Given this list of marker genes SVIP, ARHGAP42, NOD1, PLEKHA1, FYCO1, CDH10, DNAAF9, CYLD, AHR, MAP3K5, INO80B (NCBI Gene Id 83444), ZDHHC2, MUTYH, TBX2, CDK5, TTYH1, ZFYVE27, TTYH2, PLPP6, MBOAT2, SAE1, OSTM1, RBM18, ELAPOR1, BCAS3, N4BP2L1, ACTB, BCAR1, EEIG1, WIPI1, ATP13A2, RCOR2, SLC31A2, HELZ, NAV2, VPS50, ARHGAP5, SORL1, TBC1D23, PLEKHG1, TMEM151A, IFFO1, UBFD1, H2AC8, GDI1, ACBD5, ARL4A, TMEM198B, SSC5D, CCDC13, SLC17A5, MATN2, FAM174B, SH3BP4, BCHE, DAB2, TET2, BMP1, HTRA3, ULK1, IPO7, IMPA2, SYT11, MFRP, PPP2R2A, HIPK2, ZNF24, BAK1 (BCL2 antagonist/killer 1), SLC35A3, COL11A2, ATP8A1, SLC25A10, GLIS2, JAM3 (junctional adhesion molecule 3), CFAP410, PKIG, WWP2, GPR37, HECTD4, RALGDS, DHRS1, TSC22D1, ABLIM1, PIGB, PCDHB13, HELLS, PPP2R2B (protein phosphatase 2 regulatory subunit Bbeta), TPPP, PXMP4, GOLPH3L, SAMD5, CAMSAP2, ZEB2, WDR1, GLRB, HERPUD2, DBP, SYNPO, CERS6, TMEM150A, BTG1, CARD19, TM7SF3, TNFAIP6, SMPD2 (NCBI Gene Id 6610), IGSF9B, PDGFA, NBEAL1, ANKRD44, PHYHIPL, TNFRSF21, H2AZ2, FAM234B, C4A, ABCC10, TUBB4A, WDR83, CEP78, CFAP300, DCT, PAFAH1B1, TMEM108, ARHGEF25, GRB14, USP6NL, NOPCHAP1 (NOP protein chaperone 1), MALAT1, TJAP1, PCDH17, RUSC1 (RUN and SH3 domain containing 1), SEC16B, CPT1A, STRADA, COPS9, CORO7, AFAP1, TERF1, UQCC3, GAREM2, SEC14L3, ABTB1, ICMT, ATMIN, TANGO2, AK1, NREP, CDV3, PXDN, NARF, SDSL, PHLDB1, BBIP1, COL6A1, AGO4, IFI27L2, PCDHGC4, LIN54, ACAA1, VPS51 (NCBI Gene Id 739), SORBS3, BTRC, MAP6D1, SMG5, RBM12, COA8, DOCK9, H3C15, EFCAB14, ARL5B, UBASH3B, CERK, RNF128, RUFY3, NAGA, INPPL1, SLC1A1, CYB5A, RHOG, SLC2A3, PRKCQ, GRID2, DNER, TAMALIN, NKAIN1, HOMER1, GSK3B, HSPA1B, BNIP3 (NCBI Gene Id 664), MYO18A, NDUFAF3, CFAP68 (NCBI Gene Id 737), PRNP, SNX5, MYCBP, COQ3, ELAVL1 (ELAV like RNA binding protein 1), CADM2, RND2, DDR1, FOXP1, ERBIN, MBOAT1 (NCBI Gene Id 154141), H2BC11, CCDC28A, RNF144A, GAB1, BAZ2B, PARP3, S100A1, PIK3R3 (NCBI Gene Id 8503), DENND5A, COL4A5, KDM6A, MAN2B1, ATPAF1, NCAM2, IGSF11, ZMAT1, NR1D2, TXNIP, PLEC, FAM13C, MKRN1, EYA3, CCSAP, LYPD1, SERPINI1, RETREG3, CDC42EP3, LRRN3, MPZL1, CCL5, WASF1, KCNA1, KIFC2, ABCC5, NISCH, GALC, RTN4, DIPK1A, MSI2, TCTA, H3C13, INPP5E, SKIL, EPS8, SLC25A27, CEP95 (centrosomal protein 95), CCNT2, LHFPL2, LGALS9, FMNL2, SGCB, EEF1AKMT2, GADD45B, KCTD13, VAT1, TAFA2, VPS37A, MAD2L1 (NCBI Gene Id 4085), PPT1, ENPP5, MT3, TOMM20, RGS3 (regulator of G protein signaling 3), DNMT3A, THSD7A, ELDR, PDE9A, THOC2, GDF1, FKBP8, IKZF5, UGT8, CPNE2, ABI1, SEMA6D, CD81, LRP4, FAM32A, NHSL3, TMSB15B, FBXO6, JAM2, NCALD, SERBP1, AATK, DBN1, CNKSR3, LRRC8B, PRKAR2A, KLHL30, TMEM8B, CKLF, TRIO, SCN8A, TNR, MYRF, MTMR4, MAF (NCBI Gene Id 4094), SERINC5, SRGAP1, FOXP2 (forkhead box P2), PDK1, RSF1, MECP2, CDC37L1, ELOVL7, SYNGR1, ADO, MLLT11, TMEM19, ATRN, CILK1, COL9A1, FHOD3, ATL1, PACS2, TPGS2, PLEKHM3, MIR100HG, PELI1, VMAC, KIAA0586, SHISAL1, NFIC (nuclear factor I C), STAT1, HDAC9, RTL8C, PLXNB1, SLC15A4, TCF4, ZMYND8, ITPR2 (inositol 1,4,5-trisphosphate receptor type 2), SLC45A4, CD82, CACNB3, TMEM51, KCTD4, AAMDC, HIP1R, PINK1, NSD2, PARM1, GJC3, TMCC2 (transmembrane and coiled-coil domain family 2), NDRG1, SASH1, LMBRD1, TMEM88B, WDFY1, TIMP3, PEX5, SOCS6, H2AC18, SYT1, PVT1, ASTN1, ZFR, CLMN, H2BC27P, LRIG1, MYLK, COQ8A (NCBI Gene Id 56997), TIMP2, ALMS1, F8A1, SLC26A2, RNF5, NLGN3, GNAO1, CCNDBP1, PTPRM, PDGFC, ABCA2, PIGT, TMEFF1, KLHL5 (NCBI Gene Id 54163), FKBP15, NPC1, PRKAR1B, ERMARD, DCC, FRMD5, ANK3, KIAA1549, HACD2, PLXNA3, KATNAL2, TMCO6, PLK3, PURG, CREBRF, MYO5B, SOX13, TRA2A, BFAR, APPL2, DYNLT3, SMARCA2, PLXNB3, IQCE, ABHD12, SHROOM2, PNRC1 (proline rich nuclear receptor coactivator 1), MXI1, PIGQ, TMEM35A, C21orf91, SERPINA3, NAV3, AKAP10 (A-kinase anchoring protein 10), LRFN4, FZD8, HTRA1, KIAA0753, SASS6, H2BC6, DCLK1, TGFB3, ZNF703, KIRREL3, YLPM1, B3GNT2, BNIP3L, KLHL18, RUBCN, KIF21A, RHOBTB3, EHD1, ABCD4, GLTP, LYPD6, APP, CYRIB, MAP2K4, AP1S2, FCGRT, GMFB, FAM241A, LIN9, ASAP1, TTLL5, EPB41L4B, NEGR1, EPHA7 (EPH receptor A7, NCBI Gene Id 2045), ITGA7, ZBTB20, NMRAL1, NDOR1, MGAT3, TAF9B, PFN2, MARF1, MAP4K5, AGPAT4, RAD18, CNP, PDLIM2, REEP1, ENTPD5, CHADL, RAB40C, KANSL1, CSF1, PKP4 (NCBI Gene Id 8502), SLC6A6 (NCBI Gene Id 6533), JRK, ATG13, FLRT2, RECK, GNPTAB, NRCAM, R3HCC1, ATAT1, PPP1R12B, SGK2, COQ8B, HAND2, UBE2H, PLXDC2, ACOX1 (NCBI Gene Id 8308), KIF13A, LHFPL6, HLF, FUT9, TST, RANBP6, ASPA, CEP128, COL20A1 (collagen type XX alpha 1 chain), ADAMTS4, DBNDD2, SLC13A4, CYP2J2, FOS, SEMA4D, LIMS2, SOAT1 (sterol O-acyltransferase 1), DGKA, SV2A, ATXN7L2, FRAT2, GNG7, HS3ST1, TPBG, POLR1HASP, TMC7, SPAG4, MPDU1, TUBB3, TLK2, SEMA5B, TNS1, SRCIN1, SOX4, CAMK2D, INAVA, QKI, SFT2D3, YPEL3, STMP1, SORBS1 (NCBI Gene Id 80057), RAB11FIP2, BMF, TMBIM1, CCNG1, TCTN2 (tectonic family member 2), PLS1, CLIP3, PHF21B, DDX23 (DEAD-box helicase 23), SPEG, AOPEP, WDR35, SEPTIN4, BFSP2, EFCAB7, COL6A3, PCOLCE, TRIM2, MEX3B, RASSF2, PRAG1, LPAR1, TSPAN2, ZFHX3, RAD54B, YIPF4, SHB, CABIN1, ARHGAP23, SIRT2, CERS4, SLC16A7, UCP2, DZIP1, TGDS, COL6A2, GPR17, RTN2, PDLIM7, ULK2, LRRC73, GLIS3, DUSP10, SAT2, MROH3P, MGME1, AEBP1, MON2, PTPRE, SRCAP, SLC44A1, FRMD4B, MRPL15, DSCAML1, MDP1, ATP1B2, IRGM, SYT4, CTSF (NCBI Gene Id 8722), SLC22A23, MBP, CEROX1, BCAS1, H4C9, EPB41L1, SERPINB8, PDE4B, CERT1, DEPTOR (NCBI Gene Id 64798), CEP295, H1-2, ENPP2, CLCN3, NPC2, SLC30A1, MMD2, SHISA4, CIB1, PTPRZ1, SNED1, WLS, ITGB8, DALRD3 (DALR anticodon binding domain containing 3), AMD1, RABGAP1L, PIP4K2C, AKT3, ELAVL3, ENTREP1, UBXN8, ATF3, ABCA7, PCNX1, FBXO32, AAR2, KIF1B (NCBI Gene Id 57598), TMEM94, MARK1, GINS3, SOX2-OT, TCF7L1, ACSBG1, CHN2 (chimerin 2), ATP6V0A2, LRRC75A, NFKB2, URM1, ECPAS, HNRNPR, BCL2L12, CHD3, SH3D19, ACY3, DNAJB4, TMCC3, LZTFL1, NHERF2 (NCBI Gene Id 9351), RORA, HTT, REEP3, RNASEL, ZFAND5, CPEB2, SPSB1, INPP5K, SMIM14, DOCK4, RFX5, CCPG1, KLHL24, BIN3, SLC15A2, KAZN, MLLT3, BTBD17, RENO1, RFFL, DLK2, TBC1D16, KLHL29, WWP1, NFASC, ZSCAN26, MB21D2, ZKSCAN8, HMX2, ASIC1, NEDD4L, OSBPL9, REPS2, MBNL2, SLC41A2, NCAN (neurocan), HSPA4, SNX30, EBF4, PRRC2C, CTSK, MGLL, H2AC25, TNRC6B, ANTXR2, TCP11L2, PLXNC1, P4HA1, CHIC1, LDLRAD3, ARSB, SGPL1, KCNIP3, TEX2, STK11IP, ZNF267, C4orf3, DUSP7, GATM, MXD1, CASP6, PDZRN4, RAPGEF1, DNAJB14, MFSD12, SEMA4G, EPB41L2, SDF4, FGFRL1, RALGPS1, CELA1, KLHL2, GOLGA4, PER3, OPHN1, CHPT1, ERMP1, CADM1, RBM25, TUBE1, BRI3BP, SNORC, NRTN, HR, SAP30BP, S100B, PNISR, MAP1LC3B, APBA1, SLC25A42, RTTN, FGFR2, AMN1, SOCS3, SOX8, TAF13, MAP1A, BRCA1, RBBP6, GAL3ST1, GPR180, MAPRE2, APBA2, KIDINS220, AP5S1, MIF4GD, SLC2A13, TMEM216, ZFP1, HACL1, AXL, ELMOD2, PCDH19, TMEFF2, LMAN1, CHML, ZDHHC12, NEO1, FBXL3, DGAT2, RAB7B, LRRC4C, SLC48A1, CRELD1, ID4, CDH20, CMTM6 (CKLF like MARVEL transmembrane domain containing 6), TMEM63A, PRTG, POC1B, IFT22, SPTBN1, DNM3, LGALS2, STXBP3, C6orf120, PRUNE1, PLP1, IFT70B, ST8SIA1, IGLON5, EMP3, DDHD1, PHLDB2, PPP1R16B, PDCD10, ERCC4, TCF7L2, RELN, VWA5A, DOCK7, TSSC4, HEY1, GRIA2, EFHD1, PCDHB4, LRRC8C, DTNA, LHPP, TPP2, PLEKHN1, NFKBIB, IRS1, SAMD9L, GEN1, NCOR1, EZR, ZKSCAN1, CHMP1B, RICTOR, PARD6G (par-6 family cell polarity regulator gamma), ZNF445, CNIH2, TM9SF3, KLF13, CUBN, DST, BCDIN3D, KIF3C, RBM5, FKBP7, COL16A1, SPECC1, MAFA, LIPG, PRICKLE1, KCNA6, MAPT, IKZF2, MTCL2, CDK19, SAPCD1, VPS37B (VPS37B subunit of ESCRT-I), SIK1, ADD3, ALCAM, FOCAD, HSDL2, AGK, SYNE1, NCEH1, MR1 (NCBI Gene Id 3140), TMEM71, PDCD4, NDNF, CBX7, B4GALT5, COL27A1, TGS1, TBC1D22A, ANKRD12, ABHD3, ARMC6, MAU2, FYN, KCTD18, EFR3B, SPTLC2, MAP1B, RUNDC3A, DENND6B, EHBP1, NLGN2, PAK3, LATS2, USP53, JAK2, RFTN2, TMEM80, GRAMD2B, SLC5A3, TBC1D14, NHSL1, CENPW, DUSP15 (NCBI Gene Id 83747), PIGG (phosphatidylinositol glycan anchor biosynthesis class G (EMM blood group)), ZSCAN29, CPSF6, PTGDS, CORO1C, MOSPD2, LTBP1, USP20, CPM, MAPRE1, MAPRE3, METTL26, INVS, CD9, FMN2, TOR4A, TYRO3, SNAPIN, BHLHE40, PNN, DCTN3, GNB4, OGT, HDDC3, SRPK3, FA2H, NAV1, TNFSF9, KATNAL1, TTC39C, PIK3IP1 (phosphoinositide-3-kinase interacting protein 1), GALNT11, TMEM106B, LSAMP, DPYSL3, NKD1, COL4A6, PCMTD2, NASP, TCF12, UNC5B, MFAP3L, SPIN4, PPP2CA, MPV17, MINDY1, ERCC1, INO80D-AS1, FBXO44, SVIL, SCAMP2, MYO6, NIPAL3, MICAL3, TBC1D8, NINJ2, HBP1, CYTH1, DYNLL1 (dynein light chain LC8-type 1), SNRPD3, FAM193A, GIPC1, RASGEF1B, PTPRCAP, TTC5, COL11A1, BMERB1 (NCBI Gene Id 89927), LPGAT1, MTMR10, KALRN, CAPN6, TMEM30A, TMEM40, PRKCA, ADGRL3 (adhesion G protein-coupled receptor L3), SLC25A24, NOTCH1, WAC, CERCAM, FLNB, VDR, KANK1, PPM1L, RALGPS2, KIAA0930, JUN, H2BC4, PPARA, IGFBP7, DNMT3B, TRIP11, BACE1, HDAC5, ARRDC3, ZNF579, C1GALT1C1, PEX1, E2F8, CNRIP1, CFL2, TENT5A, DUSP8, HIRA, TFEB, PADI2 (NCBI Gene Id 11240), CDC42EP5, ARHGAP28, LRRC42, TTBK1, PLLP, SLC1A3, TMEM14A, VIPAS39, HADHB, BRSK1, LSM11, DDX25, ZNF32 (NCBI Gene Id 7580), PROS1, HAS2, RNF187, SCARB2, ATP6V1G2, CYP39A1, MAP6, TGFBR3, MARCKS, H2BC5, CACNA2D1, CEP192, MPP2, ALDH3B1, ANKRD28, SAT1 (NCBI Gene Id 6303), RAB3GAP2, LBP, WRN, XRN1, LRRC49, PTPDC1, IER5, MIGA2, TP53INP1, KDM5B, CCNG2, SOX21, ELF1, RAP2A, ARPC1B, CHD4, ATG4A, QPCT, MASTL, CLN8, TULP4, PIGK, SDC2, ZDHHC14, CALCOCO1, FAM53B, MOB3B, PMEL (premelanosome protein), ABHD10, TAF11, PLPPR5, PSMF1, FBXO10, DEPDC7, NDRG4, MYO1G, ACAA2, GAS7, MPI, OMG, TPP1, DIXDC1, NOL4L, THTPA, ZFYVE1, DIPK2A, TMPRSS5, STRN, ZNF365, PCDH7, SDC1, CYFIP2, ATOSB, C1QL3, RTL8B, CA14, PSPC1, BRMS1 (BRMS1 transcriptional repressor and anoikis regulator), PCDHB16, DEAF1, WSCD1 (WSC domain containing 1), DSCAM, JCAD, PAK1, RBMS1, LCORL, SPATS2L, PPP1R21, COQ10A (coenzyme Q10A), MAPK8IP3, EHD2, RETREG1, RAB2B, AMOTL2, CRYAB, ADCY9, DLGAP4, SMURF1, PIGO, SESN3, FANCB, here is a description of the gene set: Genes down-regulated during differentiation of Oli-Neu cells (oligodendroglial precursor) in response to PD174265. from publication Gobert RP, Joubert L, Curchod ML, Salvat C, Foucault I, Jorand-Lebrun C, Lamarine M, Peixoto H, Vignaud C, Frémaux C, Jomotte T, Françon B, Alliod C, Bernasconi L, Abderrahim H, Perrin D, Bombrun A, Zanoguera F, Rommel C, Hooft van Huijsduijnen R (PMID 19139271) Human Gene Set: GOBERT_OLIGODENDROCYTE_DIFFERENTIATION_DN Inadequate remyelination of brain white matter lesions has been associated with a failure of oligodendrocyte precursors to differentiate into mature, myelin-producing cells. In order to better understand which genes play a critical role in oligodendrocyte differentiation, we performed time-dependent, genome-wide gene expression studies of mouse Oli-neu cells as they differentiate into process-forming and myelin basic protein-producing cells, following treatment with three different agents. Our data indicate that different inducers activate distinct pathways that ultimately converge into the completely differentiated state, where regulated gene sets overlap maximally. In order to also gain insight into the functional role of genes that are regulated in this process, we silenced 88 of these genes using small interfering RNA and identified multiple repressors of spontaneous differentiation of Oli-neu, most of which were confirmed in rat primary oligodendrocyte precursors cells. Among these repressors were CNP, a well-known myelin constituent, and three phosphatases, each known to negatively control mitogen-activated protein kinase cascades. We show that a novel inhibitor for one of the identified genes, dual-specificity phosphatase DUSP10/MKP5, was also capable of inducing oligodendrocyte differentiation in primary oligodendrocyte precursors. Oligodendrocytic differentiation feedback loops may therefore yield pharmacological targets to treat disease related to dysfunctional myelin deposition. studied in species Mus musculus